Given this list of marker genes HPCAL1, RPP40, FAF1, FLT3LG, GKN2, CLEC1B, SLC5A8 (NCBI Gene Id 160728), FSCN3, BNIP3L, SLAMF6, LRRC41, SLC22A5, ENTREP3, CRYZL1, UBA1, SART3, REXO2, RNF187, DAD1, MYL12B, GALNS, CLIC1, CNPY3, CLDN18, NTSR2, CPT2 (NCBI Gene Id 1376), TEX56P, MRAS, PRELID3B, DMAC1, TCF3, CLDN10, TRIM25, ALDOA, TTC7B, CHURC1, XPOT, SYT17, NONO, MTX1, KIAA1191, MRM2, FGB, LYST, FGF1, SLC46A2, LENEP, C19orf48P, GCNT1, FABP3, AHCYL1, STK17B, CCN3, PAPPA, GBA1, PTPN21, GHRH, COG8, IL10RB, MEN1, NSUN4, FBXO9, DNAJB8, RARS1, USP26, RUNX2, LPGAT1, BACH2, SPHK2, NR1D2, ACOT11, PLCL2, BDH1, UMOD, ATXN7L3, ERMP1, TMEM37, CYBC1, EXT2, NUCB1, HSPA5, ATP8B3, DDX39A, SH3RF1, PHLDB2, NPY, COA6, SLC39A13, P2RY1, HELZ2, ABTB1, ATP5PF, ACADSB, REEP6, COMT, SLC25A45, YWHAQ, CCDC137, WFDC2, ATF5, RAP1A, PUS7, SNCAIP, MED20, GJB5, CAP2, JPH3, RHBDD3 (NCBI Gene Id 25807), AIMP1, UPK1A, DIP2B, TCF25, NCOA1, TLR8, HIGD2A, ARHGAP21, CLDN14, ZFP64, HAS2, ASCC1, MKNK2, PIGK, USP10, PLEKHB2, OR2C1, DCXR, NFYB, TMEM151B, B3GNTL1, ADIPOR2, CSTA, DDX4, HADH, RASSF3, KDM1A, NKG7, FBL, SLC12A1, CHRNA4, IVD, ABCB8 (NCBI Gene Id 11194), MOCS2, PRPSAP1, KLF16, PLEKHF1 (pleckstrin homology and FYVE domain containing 1), MAOA, THRAP3, PURG, DBNL (drebrin like), ZBTB45, TUBB, TRAPPC12, RETREG1, PTS, DUSP6, S100A1, QRSL1, SIPA1, TRIM34, CHI3L1, HPRT1, CHCHD7, NT5M, RASAL1, LSM1, NOTCH3, SP1, TK1, AP1B1, GLO1, TTC3, SLC19A1, DHFR, CDC16, TK2, BLOC1S5, IARS1, SELPLG, NDUFAB1, SREK1IP1, TIMMDC1, OXR1, GDNF, MVK, SCRT1, HDAC1, ZFR, NEPRO, C16orf89, RMDN3, GNL1, AKT2 (NCBI Gene Id 208), MCRIP1, GUK1, TIMM10B, CASP1, SNRNP40, KLHL22, DPH2, here is a description of the gene set: from publication Amit I, Garber M, Chevrier N, Leite AP, Donner Y, Eisenhaure T, Guttman M, Grenier JK, Li W, Zuk O, Schubert LA, Birditt B, Shay T, Goren A, Zhang X, Smith Z, Deering R, McDonald RC, Cabili M, Bernstein BE, Rinn JL, Meissner A, Root DE, Hacohen N, Regev A (PMID 19729616) Human Gene Set: GSE17721_CTRL_VS_POLYIC_2H_BMDC_UP Genes up-regulated in comparison of control dendritic cells (DC) at 2 h versus those stimulated with poly(I:C) (TLR3 agonist) at 2 h. species: Homo sapiens mouse primary BMDCs were stimulated with tlr ligands and gene expression changes were profiled on Affymetrix arrays